Given this list of marker genes Fdft1, Fdps, Hmgcs2, Plpp6, Hmgcs1, Ggps1 (geranylgeranyl diphosphate synthase 1), here is a description of the gene set: studied in species Mus musculus The chemical reactions and pathways involving farnesyl diphosphate, an intermediate in carotenoid, sesquiterpene, squalene and sterol biosynthesis, as well as a substrate in protein farnesylation. Mouse Gene Set: GOBP_FARNESYL_DIPHOSPHATE_METABOLIC_PROCESS